Given this list of marker genes PRDM12, PTMA (NCBI Gene Id 91418), ANP32E, ASF1A, HIRIP3, PWP1, SPTY2D1, NAP1L1, ASF1B, APLF, VPS72, IPO9, MYD88, JDP2, here is a description of the gene set: species: Homo sapiens Human Gene Set: GOMF_HISTONE_CHAPERONE_ACTIVITY Binding to and carrying a histone or a histone complex to unload or deposit it as a nucleosome. The histone can be newly synthesized or result from nucleosome disassembly (either spontaneously, or by a histone chaperone).